Given this list of marker genes ERCC1, POLD2, GTF2H1, POLD4, GTF2H4, UBA52, RPA2, CUL4B, POLD1, PCNA, CUL4A, RBX1, ERCC5, RPA3, RFC2, RFC5, POLK, UBB, RPA1, POLE4, GTF2H2, POLE3, CHD1L, POLE, GTF2H5, ERCC3, POLD3, PARP1, POLE2, DDB2, RFC4, ERCC2, GTF2H3, DDB1, UBC, ERCC4, RFC3, RFC1, PARP2, XPA (NCBI Gene Id 7507), RPS27A (ribosomal protein S27a), here is a description of the gene set: Reactome Pathway: Dual Incision in GG-NER part of: Global Genome Nucleotide Excision Repair (GG-NER) species: Homo sapiens Double incision at the damaged DNA strand excises the oligonucleotide that contains the lesion from the open bubble. The excised oligonucleotide is ~27-30 bases long. Incision 5' to the damage site, by ERCC1:ERCC4 endonuclease, precedes the incision 3' to the damage site by ERCC5 endonuclease.